The following is a description of a gene set: from publication Chen Y, Wang X (PMID 31504780) Human Gene Set: MIR4796_3P species: Homo sapiens Genes predicted to be targets of miRBase v22 microRNA hsa-miR-4796-3p in miRDB v6.0 with MirTarget v4 prediction scores > 80 (high confidence targets)., and this is the list of marker genes: NRIP1, LAMP3, FGD5, TMEM127, KPNA4, BRMS1L, USP9Y, ETV1, ENPP5, FBXL3, KDM5B, ZNFX1, RGMB, FZD3, RPS6KA4, RASD1, DERL2, MYT1L (myelin transcription factor 1 like), FYCO1, CYP3A5, U2SURP, PALS2, SH3PXD2A, TSC22D2, FER, BMP2, ZNF780B, RPS6KA5, UBE3C, KLHL29, CAPRIN2, EPHA4, ITPRIPL2, CEP120, DUSP2, TEDC2, WDR36, KCNK10, NIN (NCBI Gene Id 57681), TRIM36, PCM1, CD69, CDH1, HRH1, EGR3, GPR137B, LAMA3, TGFBR2, SACS, GPR6, KCNE4, PTPN4, ANO6, SASH3, NEDD4L (NEDD4 like E3 ubiquitin protein ligase), NOTCH2NLA, LCE2A, UPK2, SMURF1, CHRM2, ATG16L1, DLG4, SLC16A6, NRIP3, COPS2, PHAF1, PCSK5, FSD1L, SCARB2, TRIM3 (tripartite motif containing 3), HSPA8, ITGA4, TMEM18, SLF2, ZFP36L2, DNAJC27, C3orf70, EIF4A2, LIMK1, SLC24A2, CBLN4, RETREG3, AKAP11, DSP, API5, DOCK4, FGF12, UBE2D1, RLIM, FMNL3 (NCBI Gene Id 91010), BECN1, MAML3, LIMK2, REV3L, LYZL4, FJX1, RAB8B, LIX1L (NCBI Gene Id 128077), ESRRG, CEP170, GLUD1, ANKIB1, KTI12, USP46, RNF13, IL6ST, C6orf62, AAK1, ABCA1, EZH1, TXNIP (NCBI Gene Id 10628), ZBTB33, CBFB, HAUS8, SH3BP5, ACTR1A, DDHD1, TNFRSF21, FZD7, PCGF2, REST, FOXJ3, REL, DENND5B, ACIN1, GXYLT1, FBXL5, SLC25A13, SYT7, MED12L, ELL, ENO4, STRIP2, ZFHX3, SCN1A, TBC1D9, TENT5D, CAND1, RPUSD2, TFB1M, PURA, POU1F1, TRIP11, UNC80, ZFYVE26, CEP97, TET3, ARID4A, RAP2C, IL17RD, ANKRD42, PKD2, NUCKS1, ZFYVE9, STARD13, PPP1R3B, RIMBP2, FRMD6, CCND1, ITGB8, KLHL2, PEX5L, TRIP10, MYF5, VASP, TSEN15, EBF1, POLR3K, SAMD12, TTR, PAPLN (NCBI Gene Id 89932), ADH4, RNF128, GOLGA7, SSU72, RASL11B (NCBI Gene Id 79093), BTBD10, OSM, APPL1, MARVELD2, B2M, SERTAD2, MINDY2, GARS1, SGIP1, KLHL24, KLHL8, NFAT5, OTUD1, DLGAP1, MACF1, ZNF800, APBB2, ANKRD33B, PRR15, LDLRAP1, BTG3, SEMA4B, VANGL1, GPATCH11, EGLN3, MASTL, SSH2, ZNF561, CCL28, SLC11A2, F3, PRRG1, VASH2, FMO3, TOMM70, MTSS2, DTD1, HCN4, AIFM2, SMIM15 (NCBI Gene Id 649861), JPT1, DENND1B, PDE7A, PDZD8, MYLIP, OTUD4, ADAM9, UVRAG, NPAT, TIMM44, ARMC8, E2F5, PLEKHA3, IKZF4, PRKCA, CPQ, CRY2, RPS6KA3, RASGRF2, KCNB1, NAGK, FRS2, SESN3, CORO2B, KIF5B, FAM117B, RNF217, EAF1, GPR63, SLAIN2, SLC39A9, ERP44, AGFG1